The following is a description of a gene set: Human Gene Set: GOBP_SUGAR_MEDIATED_SIGNALING_PATHWAY studied in species Homo sapiens The process in which a change in the level of a mono- or disaccharide such as glucose, fructose or sucrose triggers the expression of genes controlling metabolic and developmental processes., and this is the list of marker genes: ADCY8, UBTF, SMARCA4, USF1, MLXIPL, SMARCB1, USF2, PDX1, PIH1D1, AGER, NKX6-1